The following is a description of a gene set: from publication Chen Y, Wang X (PMID 31504780) Genes predicted to be targets of miRBase v22 microRNA mmu_miR_7119_3p in miRDB v6.0 with MirTarget v4 prediction scores > 80 (high confidence targets). Mouse Gene Set: MIR_7119_3P species: Mus musculus, and this is the list of marker genes: Dyrk2, Ednra, G2e3, Pnisr, Tbc1d20, Ctnnd1, Zbtb6, Vrk1, Kmt2a (NCBI Gene Id 214162), Brox, Ranbp1, Dnaaf10, Igsf9b, Nwd2, Atrx, Ugcg, Hdgfl3, Ankhd1, Ccp110, Tmppe, Gm11545, Nkx2-1, Fam199x, Camkk2, Sez6l, Slain2, Syncrip, Ppfia1, Elk4, Adam22, Ppp4c, Rcsd1, Ldlrad3, Rpusd2, Rab38 (RAB38, member RAS oncogene family), Gpt2, Vangl2, Mettl9, Btg1, Csnk1g1, Nploc4, Zc3h18, Ccnl1, Eloa, Nfix, Pdap1, Gpr63, Trpc5, Secisbp2l, Pum2, Asph, Napepld, Gsn, Irs1, Rsbn1, Enpp6, Ube2j2, Clock, Mast4, Grm5, Rorb, Cxcr4, Palb2, Phc2, Gm3558, Cryzl1, Ppm1k, Gm6370 (NCBI Gene Id 622924), Rab22a, Stxbp5l, Hp1bp3, Tfam, Arid1b, Selenoi (NCBI Gene Id 97239), Spock1, Phip, Rfx3 (regulatory factor X, 3 (influences HLA class II expression)), Sall4, Naaladl2, Ssbp3, Pgap1, Usf3, Kcna6, Tm9sf3, Kmt2d, Pde6b, Dcun1d5, Fbln7, Cyp7a1, Tet3, B4galt1, Aldh5a1, Btbd8, Ncald, Dcaf8, Caprin1, Zfp113, Klf6, Mettl17 (NCBI Gene Id 69637), Myct1, Gorab, Cebpb, Neurod4, Fgf16, Ptprz1, Hspa4l, Cdc37, Ano5, Serpinb13, Dmp1, Entr1, Selenot, Vcpip1, Ppargc1a, Bbx, Psd3, Ncor1, Tox3, Tle1, Mbnl2, Kcmf1 (NCBI Gene Id 74287), Glyr1, Shroom2, Tpbg, Tfrc, Cnot6, Exoc8, Nsd3, Nr4a3, Spry4, Gria2, Stk35, Gdf10, Marcks, Map3k20, Plscr1, Zfp410, Tbl1xr1, Akap17b, Ddx21, Pabpn1, Jph1, Cldn1, Shprh, Tbc1d32, Nup210, Piezo2, Ms4a6c, Srp54c, Map7d1, Cdk12, Hacd3, Dennd2b, Slc9b2 (NCBI Gene Id 97086), Ldlrad2, Afap1, Icam5, Nedd9, Psmd2, Rreb1, Crls1, Cks1brt, Foxj2, Sytl4, Mier1, Adra2b, Plpp3, Cpsf6, Ggh, Has2, Rin2, Kdsr, Sarnp, Runx2, 1110059E24Rik, Semp2l2a, Foxl2, Rps6ka6, Arnt, Chd1, Ssr1, Papolg, Xpr1 (NCBI Gene Id 19775), Il18r1, Ptgfr, Nek7, Sgk1, Irx2, 1700066M21Rik, Gosr1, Lcorl, Cdkn2aip (CDKN2A interacting protein), Slc10a4-ps, Dnajb4, Hnrnpr, Dennd6a, Fut9, Slc5a3, Ccdc50, Zfr, Gabrb2 (NCBI Gene Id 78533), Dck, Dtna, Zbtb10, Arl8a, Sertm1, Cxcl16, Frrs1l, Rc3h1 (RING CCCH (C3H) domains 1), Gm11544, Trim6, Nipal1, Zfhx4, Erg28, Cdyl, Xkr6, Yaf2, Hipk1, Pou2f1, Aff4, Dicer1, Lrrc8a, Yy2, Cpd, Tubb3, Swap70, Cytl1, Rest, Gm3404, Kazn, Lifr, Pcsk2, Xpo1, Khsrp, Serpinb1c, Lrp12, Zfp871, Morc3, Ipo8, Rbbp4, Dhx57, Zfp300, Ptbp2, Ankrd10, Ptbp3, Tmed8, Thbs2, Pdk4, Slc16a1, Ubtf, Stimate, Tmem164, Rnf138, Dmxl1, Cyp2u1, Gpd1l, C1ql2, Ccdc34, Aak1, Tfdp2, Bcl11a, Skor1, Rgmb, Runx3, Gatm, Fubp1, Mief2, Raph1 (Ras association (RalGDS/AF-6) and pleckstrin homology domains 1), Pik3r1, Frmd3, Sun2, Azi2, Cd300lf, Sgcb, Tiam1, Sox17, Fat1, Fam168b, Parp12, Dag1, Negr1, Cadm1, Srp54a, Pde1a, Nxph4, Tmem158, Tceanc, Bmpr2, Arhgap11a, Samd8, Mtmr12, Ssbp2, Rpf1, B3galt2, Rsf1 (NCBI Gene Id 77334), Cab39, Enah, Gvin2, Trim28, Pou3f2, Zfp423, Nfatc2ip, Atxn3, Ankrd44, Armc8, Trpm1, Slc25a44, Utrn, Rwdd3, Zfp597, Casc3, 4930519G04Rik, Rgs17, Smc2, Dusp6, Tmem263, Fgfr1, Ankrd52, Rab8b, Tfcp2l1, Gask1b, Yod1, Tmed7, Neto1, Bpnt2, Inpp4b (NCBI Gene Id 234515), Hhip, Spin1, Neto2, Esco1, Tmod3, Atf1, Trip12, Trerf1, Ppp1r3b, Hsd17b13, Qrich1, Pak3, Mthfd2, P2ry4, Srsf11, Cacna2d1, Cbx3, Gata3, Trib2, Twsg1, Homer1, Mbnl1, Canx, Homer2, Gabrg1, Kctd1, Mitf, Dyrk1a, Abl2, Txnip, Usp39, Mcu, Zfp719, Ppp1r1c, Gls, P2rx4, Naa40, Arhgap12, Rwdd1, Kdm5a, Kctd10, Hapln1, Scn9a, Htr7, Ppp1r1a, Pakap, Polr1f, Rcor3, Irf4, Slc27a1, Tmx1, Bhlhe22, Pxdn, Peg10, Runx1, Ncoa7, Cdc40, Epha4, Bri3bp, Zfp84, Miga1, Ppp1r14b (NCBI Gene Id 18938), Dcbld2, Tmem132c, Pigk, Vps13d, 2510009E07Rik, Cs, Igll1, Foxn3, Ptpn2, Prkci, Map1b, B4galt6, Cxxc4, Ints3, Elavl2, Gng2, Foxp1, Lin28b, Fkbp14, Ube3c, Tbx18, Sugp2, Tm2d3, Cyp4v3, Clcn3, Sema6d (NCBI Gene Id 98780), Itfg1, Fzd3, Kdm1a (NCBI Gene Id 99982), Hoxa5, Pbx2 (pre B cell leukemia homeobox 2), Gata5, Gvin1, Cdk16, Grm4, Lekr1, Smagp, Cramp1, Mosmo, Zfp980 (zinc finger protein 980), Zdhhc17, Erap1, Slc25a37, Dnajb5, Cd36, 1700025G04Rik, Mylk, Slfn5, Tnfaip1, Tdrd3, Iws1, B4galt7, Flrt3, Smad1, Cpeb2, Nuak2, Rb1cc1, Slc6a18, Ppig, Tbx15, Asb7, Smim15, Zfp229, Fgf4, Cacul1, Btc, Mrgprb1, Sspn, Rars1, Prdm2, Hook1, Auh, Casp8ap2, Phf21a, Fam210a, Pigm, Slc7a13, Steap2, Cst6, Atp11a (NCBI Gene Id 75344), Cry1, Brd2, Cdnf, Wipi2, Stt3a, Erlin2, Chpt1, Il6ra, Atl2, N4bp2l2, Shmt2, Yipf6, Slc4a10, Jup, Tial1, Kcnk3, Ube2r2, Notch1, Zfp608, Tpgs2, Alpk3, Slc35e2, Vps13c, Ccdc3, Hdac9, Gpd2, Phf6, Lgalsl, Btg2, Skil, Rab21, Mynn, Six1, Erlin1, Pmaip1, Mrpl15, Trpc1, Tc2n, Sdc1, Unc5d, Smc6, Cacna1e, Nckap1, Samhd1, Sox9, Cibar1, Tmx3, Lmo3, Mff, Hgf, Zmat4, Mapre1, Bmi1, Zik1, Gnai3, Cmpk2, Cep15, Prr16, Psma1, Rasl11a, Safb, Tmem135, Tbc1d15, Kbtbd2, Sema4d, Zbtb44, Mef2c, Stox2 (NCBI Gene Id 71069), Arid1a, Sppl2a, Celsr2, Edil3, Pafah1b2, Kcnq5, Kmt5a, Ctdspl2, Oxsr1, Mob1b, Vamp4, Lrrtm4, Lcp1, Trp53bp2, Zswim6, Ddx5, Flcn, Scai, Ppp1r15b, Rbms3, Slc7a11, Brs3, Plat, Fnip2, Zfp462, Taok1, Get1, Plxdc2, Ube2d2a, Atp2b2, Hectd2, Kctd8, Ccser2, Etl4, Col1a1, Cbx6, Pdzrn4, Ermn, Zbtb37, Vasn, Dpy19l3, Zfp36l2, Setbp1, Adra1a, Pik3r3, Baalc, Hus1, Lrrc57, Elapor1 (NCBI Gene Id 99950), Hlf, Mapk6, Nexmif, Cox16, Ccdc47, Nedd4, Fbxo11, Mfsd9, Dtwd2, Cluh, Dipk2a, Ss18, Usp42, Foxf1, Phf11d, Cdk13, Ranbp10, Trim33, Sell, Rs1, Fbn2, Zfp609, Pcyox1l, Atp7a, Mon2, Guf1, Bpnt1, Zfp644, Sost, Gm3409, Dcun1d4, Mdfic, Ucn2, Cxadr, Sdc2, Bcl2l15, Tmem38b, Vwc2, Dnmt1, Tmem170, Akap5, Mob3b, Timm44, Tmem65, Plcg1, Ehmt1, Nr6a1, Elf5, Lpar1, Il31, Tmem237, Cand1, Prmt3, Gpn2, Vhl, Med15, Pdzd8, Zbtb39 (zinc finger and BTB domain containing 39), Amfr, Pcdhb18, Tet2, Nkain3, Hivep2, Pm20d2, Cnnm2, Acat2, Ccn2, Pfn1, Zzz3, Hoxd9, Zfp560, Rnf38 (NCBI Gene Id 73469), Socs6, Gsr, Cyth1, Trim66, Sik1, Stc1, Fli1, Zfp341, Ammecr1l, Psmd12, Son, Mtdh, Cers3, Insyn2a, Dctd, Mbd2, Tasor, Smndc1, Dock6, Abi2, Ankrd28, Cap2, Taf4b (NCBI Gene Id 72504), Ebf2, Csta1, Tnfrsf21, Etnk1 (ethanolamine kinase 1), Eef1e1, Tmem245, Marchf1, Celf2, Tmed5 (transmembrane p24 trafficking protein 5), Olfm3, Ddx42, Atp2b4, Sfmbt2, Sirt1, Slc17a5, Med14, Zmym4, Pafah1b1, Bcl10, Chfr, Slk, Socs2, Zfp26, Rps6ka5, Or51e1, Ppme1, Ago2, Pigv, Rnf2, Brd4, Pard6g, Ccny, Zfp385b, Oscar, Ivns1abp, Sumo2, Tut4, 6030458C11Rik, Dazl, Rock1, Tcl1b1, Mrpl3, Kctd12, Maml3, Galnt7 (polypeptide N-acetylgalactosaminyltransferase 7), Erbb2, Gfra1, Nckap5l, Ikzf3, Plagl1, Cdk17, Prdm1, Slc39a10, Commd8, Sos2, St8sia4, Pxylp1, Pld1, Neu4, Plekhg1, Arhgap32, Usp44, Egr3, Hoxd13, Kcnj3, Chst13, Crnkl1, Trim23, Mga, U2surp, Zfp148, Map4k3, Dennd5a, Zmpste24, Dcaf10, Tnfrsf10b, Taf7, Arhgef6 (Rac/Cdc42 guanine nucleotide exchange factor 6), Rnf111, Crebrf, Cnot7, Nsd1 (nuclear receptor-binding SET-domain protein 1), Slc52a2, Ppp6r3, Oprm1, Cggbp1, Zcchc14, Amer1, Ogt, Lnx2, Tifa, Smg7, Tmcc1, Lrrc58, Rtkn2, Pogz, Proser1, Hepacam, Mylk4, Cdh20, Wnt5a, Phf12, Zbtb1, Paip1, Map4k5 (NCBI Gene Id 78253), Ago4, Eogt, Dmc1, Gsx2, Adamts9, Gpc6, Tcf12, Ptar1, Ssh2, Eppk1, Sp3, Tardbp, Zmiz1, Insm2, Slc35g1, Stard3nl, Plcl1, Nap1l1, Med1, Carf, Fgf8, Hey2, Pdik1l, Myb, Fam117b (NCBI Gene Id 72750), Samd4, Ppp2r3c, D5Ertd579e, Tead1, Nucks1, Tsen34, Ift80, Irf2bp2, Irak2, Inpp4a, Zc3hav1l, Col19a1, Pikfyve, Tmem63b, Zfp422, Wwtr1, Sgip1 (NCBI Gene Id 73094), Rftn1, Osgepl1, Nfat5, Dstyk, Ski, Syt1, Ckap4, Rgs9bp, Sim1, Slc15a1, Ppp4r4, Gulp1, Lpgat1, Itpripl2, Kdm2b (lysine (K)-specific demethylase 2B), Tusc3, Zbtb21, Zfp697, Kdm2a, Rbfox2, Uhmk1, Nsl1, Mrgprb2, Rbm22, Tnfaip6, Pik3ca, Macrod2, Lamb1, Zfp277, Kat2b, Nrf1, Wdr90, Sar1b, Map3k2, Mucl3 (mucin like 3), Rhob, Prrt3, Ikzf5 (IKAROS family zinc finger 5), Gk5, Ssu72, Sppl3, Ccdc14, Smarcc1, Nbr1, Sf3b1, Ctnnb1, Arhgap42 (NCBI Gene Id 71544), Tspan9, Myef2, Ergic2, Hif1a, Trank1, Rara, Fgd4, Heatr1 (HEAT repeat containing 1), Ddx39b, Astn1, B3galnt2, Fbxo45, Fzd6, Kif26a, Bcl2l12, Ogfrl1, Zfp950, Aff1, Ctps1, Timd4, Septin2, Asb5, Acsl4, Tspan31, Sertad2, Rnpep, Fbxo43, Lhx9, Creb1, Marchf5, Hnrnpd, Abhd17c, Tmem106b, Sertad3, Senp5, Ambra1, Tyr, Pitpnm3, Pip4p2, Ncoa3, Ubxn7, Zmym3, Alkbh5, Rex2, Mkrn3, Tcl1b5, Cpeb4, Scn1a, Rnf6 (NCBI Gene Id 74132), Cxxc5, Grm6, Nrip3, Csmd1, Mrtfb, Actr2, Tet1, Six4, Tsc22d3, Lrrc7 (leucine rich repeat containing 7), Sephs1, Tbc1d24, Pde7a, Gfpt1, Zfp345, Ildr2, Cln8, Rab11fip1, Nphp3, Hdx, Pank3, Zfp800, Ubfd1, Znrf3, Otud7b, Pdp1, Tfap2c, Ube4b, Fras1, Nsmce4a, Rnf17, Slc39a14, Yeats2, Tor1aip2, Gmcl1, St18, Il6, Ugdh, Trps1, Fbxo28, Cd44, Myocd (NCBI Gene Id 214384), Sec24a, Ampd3, Cyb561a3, Snx25, Cux1, Ppp1r2, Birc5, Safb2 (scaffold attachment factor B2), Tmem26, Rras2, Otud4, Elavl1, Slf2, Pcdh20, Atp2b1, Lsm7, Nup50, Slc8a1, Suz12, Vamp3, Tbp, Sorbs2, Cuedc1, Asah1, Dcaf12, Smg1, Usp31, Vkorc1l1, Rbm20, Dab1, Gatad2a, Srek1ip1, Wapl, Jmy, Hapln4, Sco1, Bdp1, Slc23a2, Macroh2a2, Tnfrsf11a, Smarcad1, Nbeal1, Mboat7, Mrs2, Shoc2, Ube4a (NCBI Gene Id 338480), Phtf2, Myo10, Hars1, Pald1, Klhl7, Lbr, Perp, Siah1a, Mei4, Sfpq, Pten, Cd84, Prcp (NCBI Gene Id 72461), Zranb3, Anks1b, Gigyf1, Ets1, Mybl1, Tigd3, Nmt2, Nmrk2, Isl1, 2210408I21Rik, Osbpl8, Traip, Magi1, Rims2, Bcor, Camk2d, Klf10, Cep55, Ctnnd2, Robo1, Pcdh8, Msl2, Arhgef12, Cblb, Myt1, Rnf144a, Npas3, Slc30a7, Ptpn1, Calcr, Ttc14, Rprd2, Sp1, Aasdhppt, Tmeff1, Zeb2, Lnpk, Pfas, Rcn1, Pcbp2, Ythdf2, Tbpl1, Alcam, Plcxd2, Bnc2, Epc1, Lin7a, Acbd3, Arid4b, Hoxd8, Galntl6, Bicd1, Scara5, Zmat3, Hsf5, Prpf38b, Dnd1, Gpr165, Gabpa, Cmtm8, Fgfr1op2, Rcl1, Nufip2, Larp4, E130308A19Rik, Mex3d, Selenon, Ddr1, Ciao2a, Mbnl3, Rspry1, Dnajc6, Pdcd4 (NCBI Gene Id 28204), Bcl11b, Klhl29, Kalrn, Sox6, Phf8, Gabrp, Pard3, Pou3f1, Myc, Atp8b1, Gabra4, Dclk1, Taf9b, Trim61, Slc38a10, Smurf2, Cfap410, Bptf, Tnrc6b, Hapln3, Pde4d, Pggt1b, Adrb2, Rhobtb1, Mbtd1, Aatk (NCBI Gene Id 11302), Srebf2 (NCBI Gene Id 20788), Cyria, Cdc27, Nlk, Nadk, Nectin1, Mxd1, Rhoq (NCBI Gene Id 80836), S2bpcox16, Prkaa2, Ccdc112, Appbp2, Tmem243, Hip1, Tcl1b4, Ywhag, Zfp266, Igf2bp2, Arhgap19, Mtf2, Phactr4, D16Ertd472e, Apold1, Zbtb41, Rbm47, Nova1, Pphln1, Ube2h, Setd5, Krt222, Arglu1, Tmod2, Phldb2, Atxn1, Ube2g1, Gcnt1, Patl1, Ttbk2, Dis3l2, Ywhaz, Hecw2, Pygo1, Psme3, Bdnf, Mtss1, Iffo2, Ssr3, Pdpk1 (3-phosphoinositide dependent protein kinase 1), Fam118a, Zfx, Grk5, Eloc, Rhot1, Chl1, Luc7l2, Crebzf, Cdk19, Snx18, Thsd7a, Ano4, Map3k1, Cdk6, Ctbp1, Hapstr1, Adamts5, Pate2, Med13l, Sh3rf1, Arrdc3 (arrestin domain containing 3), Lrrc3, Gfral (GDNF family receptor alpha like), Fam133b, Phf3, Scaf8, Gm3415, C2cd3, Lrrn1, Cpsf7, Tmem92, Cts8, Stk26, Trp53inp1, Tmem101, Ccnd2, Neu3, Ino80d, Sdf4, Arhgap6, Gata2, Sypl1, Zfhx3, Ttc19, Mief1, Mmachc, Rac1, Marf1, Zfp91 (NCBI Gene Id 67567), Acvr1b, Synj2bp, Nin, Arid3a, Klhl15, Thap2, Cstf3, Sec22b, Bin1, Foxn2, Cnot4, Cyp20a1, Fam76b, Aqp3, Ror1, Etv6, Pacs2, Gli3, Zfp600, Slitrk5, Vezf1, Glipr2, Fst, Sox11, Ctif, Bach2, Gtf2f2, Galnt2, Cpxm2, Zfp407 (zinc finger protein 407), Acsl3, Gnb1, Ptprj, Cnot6l, Cnot9, Rbms2, Peli1, Cilp, Trpc3, Psmb6, Siah2, Plscr4, Grk3, Col14a1, Nfatc2, Tmem248, Slc38a9, Lmtk2, Pdlim5, Elk3, Oxr1, Mzt1, Thsd1, Ano8, Rbm26, Ntf3, Raf1, Ctbp2, Rps20, Cpne8, Mapk8, Abce1, Megf10, Acvr1, Hipk3, Adcyap1, Zranb2, Ptpn5, Top1, Rasal2, Hycc2, Ube2k, Cdk7, Rngtt, Agl, Kat6a (NCBI Gene Id 60407), Fn3k, Cep97, Cnot8, Mia3 (NCBI Gene Id 98575), Hmgxb4, Semp2l1, Atp2c1, Sf3a1, Rapgef2, Srp54b, Sox7, Fsd1l, Prkg1, Tmem70, Tcerg1, Magel2, Lrp6, Dsg1b, Slc8b1, Ube2w, Elavl4, Itgav, Aebp2, Litaf, Sncaip, Slc7a3, Ddx6, Ppp1cb, Ccdc88a, Strn3, Cul3, Eif4e, Gucy1a2, Srsf10, Mier3 (MIER family member 3), Cmpk1, Ube2j1, Tgfbr1, Sfmbt1, Csnk1a1, Mafb, Syt11, Rprd1a, Frmd7, Septin6, Gm3402, Alyref, Mfap3l, Cpeb1, Dusp10, Ppp2r5e, Rimklb, Prpf18 (pre-mRNA processing factor 18), Ophn1, Il17rd, Edem1, Kdelr1, Pan3, Gpatch2, Ids, Flvcr1, Shtn1, Scyl2, Uhrf1, Pik3c2g, Ctsc, Mrpl17, Efnb1, Avl9, Plekhf2, Cflar (NCBI Gene Id 98571), Fam107b (NCBI Gene Id 98860), Camta1, Csrnp2, Spryd7, Ikzf2, Erbin, Kpna1, Dock10, Eea1, Cfl2, Fbxo32, Abcb7, Supt16, Tafa2, Bard1, Qtrt2, Plod2, Ppp3cb, Arhgap29, Cirbp, Eif5a2, Kcnk10, Atg3, Mtcl2, Wnk3, Btg4, Tdrd5, Cadm2 (NCBI Gene Id 72986), Tbc1d16, Plekha3, Ccdc169, Decr2, Sp4, Zfp616, Mctp2, Tnfsf10, Ncoa2, Fam169a, Zfp235, Epha7, Lhfpl3, Zfp326, Ccbe1, Tcf7l1, Lin7c, Bora (NCBI Gene Id 77744), Cdk5r1 (NCBI Gene Id 52900), Gse1, Prpf4, Map4k4, Cdc26, Med13, Vps37b, Tmem175, Gna13, Zdhhc20, Vps4b, Naa50, Zbtb2, Btaf1, Nxt2, Tbck, Prpsap2, Cytip, Atad1, Lratd2, Fam171b, Satb1, Golt1b, Mpp7, Slc12a2, Arfgef3, Pros1, Ncapd2, Hnrnpl, Steap3, Prmt1, Arid5b, Dpy30, Atp13a3, Kdm7a, Adgrv1, Plaa, Borcs5, Yipf4, Sox5, Peli2, Fbxl17, Smad7, Gsk3b, Soat1, Sgms1, Epb41 (erythrocyte membrane protein band 4.1), Col25a1 (collagen, type XXV, alpha 1), Ptpre, Med18, Kmt5b, Map2k4, Dock3, Trim27, Actb, G6pc1, Emc1, Ybx1, Serbp1, Ddx10, Fgf23, Dync1li2, Azin1, Dach1, Prc1 (NCBI Gene Id 54341, protein regulator of cytokinesis 1), Atad5, Glce, Fndc3b, Ppip5k2, Krtap9-20, Ebf1, Cdkal1, Acp3, Cdh7, Dynlrb1 (dynein light chain roadblock-type 1), Map3k5, Rbm46, Zfand5, Naa30, Skp2, Rdh1, Chsy1, Fmr1, Sowaha, Lats1, Ptges3, Rasef, Kin, Pcdh15, Ywhab, Arhgef1, Rasa3, Msi2, Tfap4, Kcnj2, Mal2, Prss3b, Zbtb18, Nfia, Ing3